Given this list of marker genes FLNB (NCBI Gene Id 8413), INPPL1, FBLN5, FGFR3, RSPRY1, HNRNPH1, ANKH, LBR, IARS2, ELN (elastin), ALDH18A1, CHD4, here is a description of the gene set: Small foramen magnum An abnormal narrowing of the foramen magnum. species: Homo sapiens Human Gene Set: HP_SMALL_FORAMEN_MAGNUM